Given this list of marker genes Ppm1a, Pten (NCBI Gene Id 70161), Phlpp2, Pdxp, Ctdsp2, Ppm1d, Ppm1f, Ppp1r12a (protein phosphatase 1, regulatory subunit 12A), Rpap2, Ppp2ca, Dusp21, Dusp19, Eya1, Ppp1r16a, Ppp1r12c, Dusp26, Ublcp1, Ppp1r16b, Dmpk, Dusp8, Ppm1m, Ppm1g, Dusp12, Ssh2, Ssu72, Dusp13b, Ppm1j, Dusp23, Ppp5c, Ppp3cc, Pgam5, Cdkn3, Ppp2cb, Ppm1n, Dusp4, Ctdsp1, Ppm1h, Ctdspl, Ppm1l, Dusp13a, Dusp6 (NCBI Gene Id 67603), Dusp18, Ssh3, Pptc7, Dusp15, Ssh1, Cpped1, Dusp14, Dusp2, Ppp1ca, Dusp3, Phlpp1, Dusp28 (NCBI Gene Id 98616), Ppp1cb, Cdc14a, Ppp3ca, Ppp3cb, Ppm1k, Ppp1r12b, Ptpmt1, Dusp10, Smtnl1, Ppp6c, Ctdp1, Ctdnep1, Epm2a, Ppp1cc, Ppm1e (NCBI Gene Id 327991), Ppm1b, Cdc14b, Ilkap, Dusp29, Dusp1, Ppef1, Ppef2, Ppp4c, Dusp22, Dusp7, here is a description of the gene set: species: Mus musculus Catalysis of the reaction: phosphomyosin + H2O = myosin + phosphate. Mouse Gene Set: GOMF_MYOSIN_PHOSPHATASE_ACTIVITY